The following is a description of a gene set: studied in species Homo sapiens Abnormal circulating renin concentration Human Gene Set: HP_ABNORMAL_CIRCULATING_RENIN_CONCENTRATION A deviation from the normal concentration of renin in the blood, a central hormone in the control of blood pressure and various other physiological functions., and this is the list of marker genes: KCNJ16, SEC61A1, CYP11B1, SCNN1B, AVPR2, CYP17A1, HSD11B2, MAGED2, CACNA1D, CYP11A1, SLC12A3, CASR, KCNJ1, NNT, HSD3B2, NR3C2 (NCBI Gene Id 4306), MC2R, CLCN2, KCNJ10, SLC26A3, SCNN1A, SCNN1G, CLCNKB, POR, SLC12A1, CLCNKA, WNK1, MRAP, BSND, INSR, CYP11B2, KCNJ5, GNAS